The following is a description of a gene set: species: Homo sapiens Human Gene Set: GOBP_SKELETAL_MUSCLE_ORGAN_DEVELOPMENT The progression of a skeletal muscle organ over time from its initial formation to its mature state. A skeletal muscle organ includes the skeletal muscle tissue and its associated connective tissue., and this is the list of marker genes: GTF3C5, MYOD1, SVIL, ABCC9, PPP3CB, NPHS1, MYOZ2, WNT10B, FKRP, MYORG, BCL9L, P2RX2, MEF2C, EMD, PAX7, WT1, HMG20B, CDON, ACTN3, SMYD1, MCUB, PRKAA1, HDAC9, TGFB1, MYH15, METTL21C, LEMD2, ERO1A, ANKRD33, KEL (NCBI Gene Id 3792), CACNA1S, SPG11, GPX1, MYOCD, DMRTA2, TCF21, B4GALNT2, VRK3, SIX4, BVES, NUPR1, MSC, BCL9, IGF2, EEF2, DES, CHRND, S100B, NR4A1, SHH, CDK5, EOMES, ACTA1, SKIL, MED20 (NCBI Gene Id 9477), MYF5, RHOA, CSRP3, EP300, FOXL2, DISP1, ASNSD1, CFL2, DAG1, NACA, MYH14 (myosin heavy chain 14), NLN, MYOM2, MYL3, PITX2, VAMP5, MYOM1, ELN, XK, PHOX2B (paired like homeobox 2B), CAV2, BASP1, CNTFR, POPDC2, LARGE1, MYC, MYOG, YBX3, CITED2, MSTN, SCX, BARX2, EGR2, SCN11A, HOXD10, ANHX, UQCC2, CYP26B1, MAFF, SIRT2, ANKRD1, CAV1, AKIRIN1, ATF3, MYOZ1, PPIF, PITX1, EPHB1, SMO, FLOT1, LMOD3, HOMER1, STAC3, TLL2, FKTN, HOXD9, SOX8, ZBTB18, SIX1, NR1D2, WNT3A, CFLAR (NCBI Gene Id 8837), KLHL41, MYL11, USP19, SRPK3, CHRNA1, NF1, SOX11, KAT8, HSD17B1, KLF5, RB1, PLEC, FLNB, EGR1, CCNT2 (cyclin T2), TWIST1, FOXN2, HLX, FOS, KRAS, COPS2, PPP3CA, CTNNB1, HEYL, MYF6, FXR1, FGFRL1, GPC1, GPCPD1, MYL6B, COL19A1, STRA6 (signaling receptor and transporter of retinol STRA6), RYR1, COL6A1, PAX5, SHOX2, VPS54, MAPK14 (mitogen-activated protein kinase 14), NR2F2, GMPPA, VAX1, BMAL1, ZNF689, HIVEP3, POPDC3, FBXO22, VGLL2, DNER, MEGF10, NEGR1, IGSF8, ASS1, MEOX2, NEURL1, DMD, DDX17, BTG2, KLHL40, MYL6 (NCBI Gene Id 4637), MYLK2, FOXP2, NOTCH1, CNTNAP1, DLL1 (NCBI Gene Id 28514), DDX5, RBM24, SELENON, TBX1, SAP30, MYMX, MIR1-1, BCL2, BIN3, MTM1, CASQ1, RCAN1, ASB2, SKI, HLF